Given this list of marker genes Ceacam1, Cldn34d, Btla, Lilrb4a, Atxn3, Rab1a, Pcdhb15 (protocadherin beta 15), Ager, Tfe3, Il1rap, Klra1, Thy1, Blm, Itga10, Irf1, Cldn2, Cebpb, Cd200l1, Ptpn1, Tek, Cd74, Rell2, Vtn, Loxl3, Cd24a, Zbtb7b, Whamm, Hsd17b12, Cd69, Cd84, Plg (plasminogen), Nf2, Ptprs, Zfhx3, Dlg1, Ripk2, Hsph1, Pxdn, Pik3r1, Ecm2, Cxcr4 (NCBI Gene Id 12767), Cntn2, Abca12, Pcdhb6, Igsf5, Frmd5, Col26a1, Xbp1, Rela, Dmd, Tjp2, Pten, Dnaja3, Pcdh15, H2-DMa, Sorbs1, Ppm1f, Rdx, Pcdhb17, Smarcc2, Smarcb1, Pcdh20, Fadd, Bcl6, Zdhhc2, Samt3, Igfbp7, Frem3, Il23a, Bmp5, Angptl3 (angiopoietin-like 3), Rreb1, Klra6, Cldn17, Nlgn3, Stx4a, Stx3, Plxnb2, Ptprz1, Dsg2, Syk, C1qtnf1, Cdh6, Cldn34b2, Sox2, Tmem131l, Klc1, Klf4, Gimap3, Siglecg, Tescl, Cd274, Igdcc3, Hrg, Coro1a, Itga5, Nrxn1, Cd226, Cdh5, Itgb7, Lif, Mpdz, Folr2, Sdk1, Nptn, Itga2b, Vit, Nuak1, Mmp14, Hlx, Pcdhb19, Rras, Cldn8, Sema4d, Adam5, Rnase10, Atp2c1, Myot, Tnfsf14, Cadm1, Kifap3, Parva, Eng, Cdh1, Cyld, Cldn5, Smad6, Fbn1, Abl2, Cldn16, Itgb2l, Tgfbr2, Gldn, Nrarp, Col6a2, Slc6a4, Cldn34c5, Cd1d1, Tln1, Parvb, Gas6, Ncam1, Ptger4, Il2ra, Acvr1, Pla2g2a, Mdga1 (MAM domain containing glycosylphosphatidylinositol anchor 1), Tnn (NCBI Gene Id 329278), Dusp26, Il18, Elfn1, Rs1, Bmp10, Acp5, Rasa1, Cadm4, Mag, Crisp2, Trem1 (triggering receptor expressed on myeloid cells 1), Wnt5a, Arg1, Bmi1, Slk, Nectin2, Cd55, Rhoa, Lyve1, Kirrel2, Ythdf2, Akt1, Cdhr17, Plek, Pdgfra, Boc, Hoxd3, Pcdhb9, Fat4, Dlg4, Col15a1, Sorbs3, Casp3, Cbfb, Jag1, Pcdh7, Lmln, Mapk14, Pcdhb1, Peli1, Skint1, Ilk, Mxra8, Tenm3 (teneurin transmembrane protein 3), Pag1, Sema5a, Adamts9, Cd99l2, Aqp4, Cldn11, Dpp4, Fmn1, Ctnna3, Klra3, Cbln1, Pkn2, Tnfaip3, Btnl2, Adam15, Slitrk1, F2rl3, Adgrv1, Marcks, Myo10, Mdga2, Csta2, Emilin2, Crnn, Shb, Neo1, Pde3b, Shc1, Rock1, Sox13, Ptpn22, Bad, Ppp3ca, Tfrc, Map2k1, Smarcd2, Muc4, Tjp3, Palld, Mypn, Cdh2, Axl, Lamb3, Pcdhgb2, Parvg, Cyth3, Rag2, Kif26b, Pcdhgc4, Cdh24, Scgb1a1, Fgl1, Rtn4, Cldn34c2, Dmtn, Gnrh1, Wnt1, Cask, Lag3, Scrib, Pdpk1, Hoxa7, S100a9, Cplane2, Ptprc, Olfm4, Il12b, Wnt7b, Spg7, Unc5d, Macf1, Adam10, Cytip, Cd46, Plpp3, Flot1, Clasp1, Cd3e, Dhps, Adam12, Epcam, Pcdh9, Adk, Ephb1, B2m, Sparcl1, Itgad, Pcdhgb1 (protocadherin gamma subfamily B, 1), Lypd3, Ppp1cb, Pawr, Nectin4, Tmem8b, Ctla4, Cldn10, Cd28, Alox12, Nlgn2, Cyth2, Clec7a, Gpnmb, Tgfb1, Pik3r2, Cd80, Pstpip1, Wnt4, Cyp1b1, Stk10, Elane, Irak1, Actn2, Lama3, Pcdhb5, Smarcd1, Cdhr2, Sfn, Zbtb1, Ywhag, Rap2b, Gata1, Cntn1, Actn1, Pcdhgb6, Sema3e, Cstdc5, Podxl, Ccl19, Cntnap1, Cd9 (CD9 antigen), Cldn19, Igsf21, Prkd2, Npy2r, Comp, Hmgb1, Fut2, Prlr, H2-Ab1, Brd2, Cldn13, Ptk2b, Spon2, Pcdhb16, Pcdhb4, Nlrp3 (NCBI Gene Id 216799), Thbs1, Trpm7, Ctnnal1, Col1a1, Icam4, Dpt, Rc3h2, Lgals3, Myo1g, Il7, Cdon (cell adhesion molecule-related/down-regulated by oncogenes), Ccdc88b, Ccl21d, Col7a1, Fbln1, Cd300a, Ret, Cuzd1, Rhod, Dscaml1, Traf6 (TNF receptor-associated factor 6), Cd22, Ccl28, Bcr, Reln, Hapln2, Nfasc, Twsg1, Pcdha10, Vcl, Tyk2, Pdia3, Ctnnb1, Colec10, Cldn6, Cfl1, Bmp7 (NCBI Gene Id 12162), Cd59a, Tspan32, Lrrc7, Cdhr5, Smarce1, Cdh3, Shh, Ccn6 (cellular communication network factor 6), Cntn6, Omg, Cdhr4, Havcr2, Ap3b1, Prkg1, Ccn1, Itgb8, Tinag, Dtx1, Fzd4, Apoa4, Ninj2, Acan, Csf3r, Ccl2, Cgref1 (cell growth regulator with EF hand domain 1), Flrt1, Prtg, Itgb3, Pcdhb22, Pck1, Pip5k1a, Zfp609, Vinac1, Nf1, Fgb, Pdcd1, Efs, Smarcc1, Spry4, Col12a1, Flna, Mpzl3, Kdr, Muc21, Xcl1, Fer (FER tyrosine kinase), Vamp3, Lrp1, Pcdha8, Itgav, Tnxb, Defb21, Rgcc, Dsc3, Cdhr3, Rara, Il1rn, Marchf7 (membrane associated ring-CH-type finger 7), Bmp2, Tnfsf9, Ptpra, C2cd4b, Slfn1, Epdr1, Svep1, Samt1b, Jam3, Mex3b, Jak3, Dnajb6, Pcdhga8, Itga2, Vwa2, Dusp3, Lpp, Zdhhc21 (NCBI Gene Id 68268), Itgae, Pgm5, Rom1, Il1rl2, Ext1, Slitrk5, Cntnap2, Chl1, Cd276, Pld2, Bag4, Tnfaip6, Jup, Vmp1, Ajuba, Fgg, Cadm3, Kat5, Pik3cb, Dbn1, Hsp90aa1, Ttyh1, Ntm, Calr, Ibsp, Arid2, Map4k4, Cd209c, Perp, Glycam1, Tnfsf13b, S100b, Itga11, Itga6, Mybpc3, Chst2, Lims1, Grhl2, Bcl2l11, Tor1a, Itga8, Fam107a, Cd200l2, Slc4a2, Pcdha7, Spock2, Ptpn2, Klhl22, Spaca4, Ntn4, Crk, Cldn34c1, Nr5a2 (NCBI Gene Id 52226), Tmigd1, Slitrk2, Cdh13, Cntn5, Stxbp1, Fndc3b, Nck2, Pard3b, Nat8f3, Ntng1, Celsr1, Prkar1a, Erbb3, Il21, Lgals9 (NCBI Gene Id 16859), Maea, Lef1, Itga9, Psen1, Ntn1, Tiam1, Fbln5, Vwc2, Plekha2, Anxa9, Nat8f2, Pcdhb12, Aoc3, Tacstd2, Nrp1, Malt1, Nfat5, Gm1123, Foxo3, Dchs1, Msln, Epha8, Plau, Stat5a, Siglecl2, Siglec1, Pcdha6, Cldn23, Plcb1, Rasal3, Pdia2, Jam2, Fbln2, Spag6l (NCBI Gene Id 50525), Srpx2, Dusp1, Cass4, Wnt10b, Stfa3, Ppp1r12a, Pcdha4, Lama2, Ache, Vwf, Htr2a, Il2rg, H2-Ob, Swap70, Mertk, Kank1, Elfn2, Lrfn4, Adam2, Pbrm1, Afdn, Slc4a1, Actg1, Ubash3a, Il6ra, Socs5, Ncam2, Nedd9, Pcdhb14, Rpsa, Il15, Cldn15, Madcam1, Azgp1, Dusp10, Il1b, Gstp1, Ly9, Pcdh8 (NCBI Gene Id 73497, protocadherin 8), Nat8f5, Pcdhga12, Pcdh10, H2-Eb1, Ccl21a, Tgfb2, Efna5, B4galnt2, Thbs2 (thrombospondin 2), Skap1, Dlg5, Piezo1, Itgb6, Dag1, Ptk7, Dll1, Pcdhgb5, Fut7, Rsu1, Itgb2 (integrin beta 2), Epb41l4b (NCBI Gene Id 54357), Tnc, Pbxip1, Efna1, Bmx, Selp (selectin, platelet), Nrxn3, Flrt3, Ldb1, Fermt1, Omd, B4galt1, Pcsk5, Vegfa, Adam17 (NCBI Gene Id 236174), Stab1, Klra5, Sart1, Dchs2, Lck, Arg2, Clca2, Fat3, Epo, Col28a1, Cyfip2, Ptafr, Trip6, Mfge8, Aggf1, Adamts12, Egfr, Pkhd1, Siglech, Cd47, Egfl7, Zc3h12d, Tcam1, Ift74, Hyal3, Nat8f1, Klra7, Sspo, Adam19, Cdh16, Megf9, Adipoq (NCBI Gene Id 11450), Pcdhb2, Irgm1, Lamb1, Mad1l1, Kirrel3, Fblim1, Zfp35, Ppia, Spta1, Tenm2, Spock1, Cldn22, Ctsg, Cdh20, Egfl6, Atm, Tmem102, Flot2, Hapln1, Stxbp3, Pcdhb7, Cxcl13, Icam1, Ccn3, Cd27, Amelx, Acer2, Itga7, Hpse, Ppp1ca, Crtam, Add2, Socs6, Cdhr18, Plaur, H2-DMb1, Epha3, Enpp2, Nrxn2, Ctnna2, Cdh8, Mfap4, Pcdha5 (NCBI Gene Id 12941), Egflam, C2cd4a, Tnfsf4, Pcdhga5 (protocadherin gamma subfamily A, 5), Slamf1, Pcdhac2 (protocadherin alpha subfamily C, 2), Cblb, Angpt2, Fgfrl1, Fbln7, Hspb1, Ccl5, Umod, Itgb5, Ptpru, Fut1, Spint2, Msn, Adam3 (ADAM metallopeptidase domain 3), Tln2, Sirpa, Camsap3, H2-Eb2, Ackr3, Entpd1, Ccr7, Csta3, Mybph, Npnt, Atp5f1b, Ccdc80, Astl, Igfals, Tnr, Pcdh17, Otoa, Tjp1, Il6, Emp2 (epithelial membrane protein 2), Dscam, Crb2, Selplg, Pcdhga11, Lama4, Dock8, Bcan, Epha1, Hmcn1, Cx3cl1, Clstn2, Muc1, Mslnl, Ephb4, Il10, Bmp6, Utrn, Hes1, Pml, Lamc1, Cldn18, Dapk3, Col8a2, Aif1, Igdcc4, Antxr1, Dst, Prkcd, Gcnt2, Robo1, Vsig4, Dsg4, Sell, Vsig10l2, Slc7a11 (solute carrier family 7 (cationic amino acid transporter, y+ system), member 11), Cd34, Emb (NCBI Gene Id 218679), Sox4, Smoc2, Spn, H2-Oa, Ccl21e, Cdh11, Dab2, P2ry12, Izumo1, Anxa1, Itgb1, Cspg5, Ephb2, Cd6, Pcdhga3, Dock1, Siglecf, Slc7a1, Pcdh1, Mir326, Ephb6, Ambn, Dcc, Cxcr3, Magi2, Has2, Mog, Rac3, Pdpn, Stfa2l1, Ap3d1, Kng2, Cxadr (NCBI Gene Id 70446), Mfsd2b, H2-T23 (NCBI Gene Id 15040), St6gal1, Taok2, Sulf1, Col14a1, Dsc1, Pkp2, Cd59b, Cela2a, Ppard, Dlg3 (discs large MAGUK scaffold protein 3), Stab2 (stabilin 2), Ambra1, Amigo3, Ctnnd2, Ephb3, Carmil2, Cntnap5c, Aplp1, Wnk1, Tnfrsf12a, Erbb2, Lyn, Ric8a, Cdhr1, Mmrn2, Cstdc6, Vezt (NCBI Gene Id 215008), Disc1, Ifng, Plxnc1, Tnfrsf13c, Anxa2 (NCBI Gene Id 12306), Sdk2, Nexmif, Pcdhb8, Cwh43, Hapln3, Plekha7, Cd53, Npy, Ass1, Tesk1, Plxnb3, Zan, Wdpcp, Cldn34a, Sema6a, Fndc3a, Megf10, Zfp469, Tsc2, Bcl10, Sox12, Kit, Gpr4, Cadm2, Cldn3, Il1a, Epha5, Cdh15, Gm5849, Cd96 (CD96 antigen), Gata5, Myf5, Notch4, Src, Gli3, Lgals8, Cfh, Capn1, Cdh19, Cdh18, Apoa1, Crb1, Cdh10, Pcdhb11, Col19a1, Prdx2 (peroxiredoxin 2), Ufl1, Il12rb1, Fbxo38, Cdh23, Ripor2, Pcdha11, Foxf1, Ncan, Dgcr2, Fut4, Sash3, Gpc4, Sele, Igf1, Pcdhga2, Adam32, Col6a6, Arl2 (NCBI Gene Id 80563), Dact2, Pkp4, Slc39a8 (NCBI Gene Id 99532), Il4ra, Rapgef1 (NCBI Gene Id 352977), H2-Ea, Vtcn1, Celsr3, Zc3h8, Pecam1, Bcar1, Lrp6, Cited2, Siglece, Runx3, Tenm4 (NCBI Gene Id 97426), Cdh4 (cadherin 4), Il12a, Cldn34b4, Esam, Cercam, Pcdhgc5, Vav3, Tespa1, Spam1, Atp4b, Izumo1r, Itpkb, Itgbl1, Cd177, Pcdh11x, Cfdp1, Efnb2, Epha2, Cldn9, Ptpn6, Astn1, Plet1, Cdh26, Lims2, S1pr1, Tnfsf18, Gpm6b, Nid2, Fap, Edil3, Nectin1, Itgax, Gcnt1, Ppara, P4hb, Fat1, Cntn4, Dlc1, Ccl25, Egr3, Fut9, Gtpbp4, Cldn34b1, Cdk5r1, Cldn7, Col18a1, Pcdhga9, Chst4, Plxnd1, Lrp12, Spp1, Scarf1 (NCBI Gene Id 385602), Gp6, Bcl2, Efr3a, Lilrb4b, Lrrc4c, Dsc2, Col6a4, Cd164, Fermt2, Klra4, Lrrc4, App, Hapln4, Adgrg1, S100a8, Cd2ap, Dennd6a (NCBI Gene Id 211922), Smarca4, Amtn, Col5a1, Tsc1, Clec4g, Serpine1, Specc1l, Zc3h12a, Ada, Rnd1, Mia, Card11, Thsd1, Cd200, Ptk2, Zfp703, Ptprt, Pcdh18, Lrp5, Prickle1 (NCBI Gene Id 68784), Pcdhb13, Scarf2, Cldn12, Smad3, Glmn, Rac1, Fat2, Adamts18, Tbx21, Lypd11, Srf, Btn2a2, Dapl1, Clstn1, Nfkbid, Rpl29, Mdk, Aatf, Acvrl1, Myadm, Ccn2, Il4i1, Prkcz, Cd1d2, Rcc2, Il20rb, Cldn34c4, Tyro3, Runx1, Ap1ar, Frem2, Mpzl2, Myh10, Serpine2, Adam18, Pcdh19, Sec1, Tnfrsf18, Ido1 (indoleamine 2,3-dioxygenase 1), Lgals1, Vsir, Tgfbi, Plxnb1, Cdh9, Lep, Vps33b, Hfe, Klhl25, Ccn4, Triobp, Dlg2, Pcdhb20, Csta1, Nlgn1, Tnfaip8l2, Zp3, Angpt1, Lama5, Pip5k1c, Sdc3, Nckap1l (NCK associated protein 1 like), Strc, Sdc4, Smarcd3, Ihh (Indian hedgehog), Nrcam, Prkca, Cd209e, Tbx18, Atp1b1, Nexn, Tspan9, Folr1, Efnb3, Il1rapl1, Arvcf, Lax1, Mia3, Pnp, Socs1 (suppressor of cytokine signaling 1), Itgam, Hacd1, Col6a1, Hyal1, Gla, Col5a3, Laptm5, Notch1, Cdk5, Dsg1a, Fzd7, Pcdhga1, Col8a1, Lrrc32, Tesc, Dsp, Gpam, Arid1a, Sympk, Itga3, Cav1, Jak2, C1qbp (NCBI Gene Id 28127), Bmp4, Dicer1 (NCBI Gene Id 68462), Cstdc3, Gnas, Mettl3, Gfus, Srcin1, Cd86, Samt2b, Ccr2, Arhgap6, Cyrib, Mink1, Rap1gap, Lgals3bp, Pcdha1, Foxc2, Mbp, Igsf9, Tnfrsf21, Itgb1bp1, Robo4, Slitrk3, Kirrel1, Gp9, Ctnnd1, Pkp1, Ildr2, Ninj1, H2-M3, Actb, Kng1, Pcdhga6, Nphs1, Tpm1, Tmem47, H2-Aa, Rhpn1, Adtrp, Gsk3b, Stfa2, Cirop, Prph2, Dab1, Cd36 (CD36 molecule), Cd5, Erf, Gata3, Nr4a3 (nuclear receptor subfamily 4, group A, member 3), Il7r, Cstdc4, Phf10, Col6a3, Epha4, Spon1, Cx3cr1, Igfbp2, Adgre5, Pcdhga4, Spi1, Cntnap5a, Pcdhga7, Cldn24, Stfa1, Abl1, Mcam, Bcam, Eda, Adam9, Fga, Cd4, Tubb1, Limch1, Wnt3a, Prkce, Rhoh, Atp1b2, Cdh12, Kitl, Il36b, Cd244a, Onecut2, Ccl21b, Pcdha2, Flrt2, Agt, Cd160, Pla2g2f, Actn3, Troap, Actn4, Smad7, Frem1, Pla2g5, Selenok, Prkx, Actl6a (NCBI Gene Id 99742), Robo2, Il6st, Ubash3b, Ezr, Postn (periostin, osteoblast specific factor), Kif14 (kinesin family member 14), Cldn34c6, Cdh7, Cntn3 (contactin 3), Rbpj, Emilin1, Prkcq, Abi3bp, Mmp24, Mad2l2, Nt5e, Apod, Sned1, Cd33, Cldn14, Adgrl1, Itga4, Nkap, Apbb1ip, Zfp36l1, Tnfsf11, Bst1, Grid2, Cd44, Clasp2, Smarca2, Gp5, Trpv4, Prex1, Serpinb8, Fcho1, Ntng2, Braf, Ston1, Snai2, Pkd1, Cib1, Pcdhb3, Grem1, Cldn34c3, Pla2g2d, Ccr5, Sfrp1, Cbll1, Icos (NCBI Gene Id 54167), Alox5, Opa1, Fn1, Tecta, Tnf, Tm9sf4, Nectin3, Klra8, Zyx, Actl6b, Cd2, Jak1, Men1, Pvr, Golph3, Cdh17, Cd93, Col16a1, Onecut1, Tnfrsf14, Ptprj, Sh2b3, Agr2, Pxn, Ptprm, Hepacam, Lypd10, Cdc42, Cd200r1, Dsg1c, Zmiz1, Tbcd, Akna, Chrd, Ank3, Cntnap5b, Pdgfb, Pdia4, Emcn, Lpxn, Mapk7, Mybpc2, Lamb2, Mip, Efnb1, Tgm2, Kifc3, Myh9, Ptpn11, Igsf9b, Magi1, Bhlha15, Cdk6, Arpc2, Nodal, Dmp1, Ptprk, Map2k5, Ascl2, Cldn1, Phldb2, Dusp22, St3gal4, Hspg2, Pik3r6, Pde5a, Pcdh12, Ptprd, Pf4, Igsf11, Epb41l5, Ctnna1, Epha7, Samt4, Lamc2, Col6a5, Ifnb1, Igf2 (insulin-like growth factor 2), Amigo1, Il4, Stk4, Cd37, Jag2, Carmil1, Thbs4, Adam23, Pcdha3, Cd63, Itga1, Slc23a2, Efemp2, Inppl1, Pdcd1lg2, Pcdha12, Coro1c, Myoc, Vcan, Pdia6, Apc (APC, WNT signaling pathway regulator), Dnm2, Cd81, Rhob, Samt1d, Akip1, Pcdhac1, Gp1ba, Icosl (icos ligand), Calca, Mmp2, Spink5, Pcdhb21, Samt2, Ptpn23, Cd40lg, Olr1, Astn2, Dsg1b, Pcdha9, Ccl21f (NCBI Gene Id 100504346), Ep300, Vnn1, Rag1, Ndnf, Hmcn2, Cxcl12, Col4a3, Pycard, Pard3, Alox15, Tesk2, Negr1, Spaca7, Itgal, Gp1bb, Podxl2, Cd209d, Itgb4, Foxj1, Brd4, Mpz, Pcdhga10 (NCBI Gene Id 93722), Lrfn5, Sftpd, Jaml, Alcam, Lrfn3, Cripto, Smoc1, Sox9, Col13a1, Ceacam2, Adora2a, Rgmb, Pcdhgb7, Cldn4, Pcdhb18, Bsg, Flg2, Iqgap1, Fstl3, L1cam, Jcad, Ssx2ip, S100a10, Adgrl3, Ptn, Bves, Brd7, Rc3h1, Mmrn1, Itch, Zfp608, Thbs3 (NCBI Gene Id 21827), Lamc3, Pcdhgc3, Mkln1, Dock5, Hspd1 (NCBI Gene Id 15510), Rin2, Stat5b, Mmp12, Pkp3, Cdh22, Icam5, Lrrc4b, Zap70, Ndfip1, Col3a1, Il3, Prnp, Amigo2, Fyb2, Rasgrp1, H2-DMb2, Dsg3, Hes5 (NCBI Gene Id 15208), Csf1, Unc13d, Megf11, Vcam1, Nrg1, F11r, Faf1, Lgals2, Cd55b, Fgl2, Ajap1, Nfkbiz, Slit2, Nid1, Tigit, Cdkn2a, Pmp22, Nck1, Tarm1 (NCBI Gene Id 245126), Micall2, Clstn3, Rac2, Dysf, Ets1 (E26 avian leukemia oncogene 1, 5' domain), Coro2b, Foxp3, Lrg1, Cttn, Tnip1, Cdsn, Prkaa1, Pde4d, Ccm2l, Lsamp, Cntnap4, Rps3, Pcdhb10, Ceacam5, Icam2, Ccn5, Cldn34b3 (claudin 34B3), Peak1, Fermt3, Vav1, Bloc1s4, Radil, Meltf, Ddr1, Fes, Poldip2, Pcdhgb4, Nat8, Crkl, Pear1, Tmx1, Farp2, Lama1, Adam8, Pnn, Myo1f, Il2 (NCBI Gene Id 16183), Celsr2, Gimap5, Cd83, Ptprf, Klra2, here is a description of the gene set: Mouse Gene Set: GOBP_CELL_ADHESION The attachment of a cell, either to another cell or to an underlying substrate such as the extracellular matrix, via cell adhesion molecules. species: Mus musculus